The following is a description of a gene set: Human Gene Set: HP_ABNORMALITY_OF_THE_CHIN An abnormality of the chin, i.e., of the inferior portion of the face lying inferior to the lower lip and including the central prominence of the lower jaw. Abnormality of the chin studied in species Homo sapiens, and this is the list of marker genes: BSCL2, PRKAR1A, RMRP, BRAF, FBXL4, VAC14, SETBP1, RAI1, ESAM, SOX11, PIGB (phosphatidylinositol glycan anchor biosynthesis class B), GPR101, LIMK1, PIGY, PTCH1 (NCBI Gene Id 8015), SLC37A4, IL6ST, H4C5, FN1, SLC25A24, CLIC2 (NCBI Gene Id 1193), FBN1, HS2ST1, MESD, DLK1, MEF2C, PMM2, TRIP12, IGF2, GRIA4 (NCBI Gene Id 2893), RERE, STAG2, FLNA, ERCC1, SLC26A2, NGLY1, TFAP2A, SELENON, LUZP1, SLC35A2, APC2, IL11RA, OBSL1, MYH7, HNF1B, FBXO11 (NCBI Gene Id 80204), POLR3A, THOC6, LMNB1, NFIA, TWIST1, CRELD1, PIGU, SMS, DDX59, EIF2S3, STT3A, ZNF526, PCGF2, BICRA, CHRNE, KAT5, P4HTM, NEXMIF, KCNH1, SPOP, GTF2I, GJA5 (gap junction protein alpha 5), FIG4, MYH3, FGD1, GORAB, HERC1, GNB2, PTCH2, UBAP2L, SPECC1L, TAF1, TBX22, SH3PXD2B, COX7B, ZFX, TONSL, CACNA1G, TTC5, IL1RAPL1, CTCF, MEIS2, FLCN, MYH8, EIF4H, IQSEC2, FGF3, GRB10 (NCBI Gene Id 9769), NHS (NCBI Gene Id 907), COA6, SPRED2, AGPAT2, PRDM16, CAVIN1, PRKCZ, OCRL, ARID1B, HRAS, FBXW11, NDUFS4, CHRNG, ATAD3A, UPF3B, NSD2, U2AF2, RNF125, MAN2B1, MBD5, ZNF148, FBXO31, CDC42BPB, DYRK1A, SMC3, MEG3, SRCAP, CHD1, KCTD1, SCUBE3, PTF1A, SLC12A2, ANKRD11, TPRKB, RNF13, CCDC8, MAN1B1, PLOD3, OPHN1, GPC3, NALCN (NCBI Gene Id 93074), SLC6A17, MRAS, PDPN, ERCC4, EHMT1, MTOR, PIGO, TUBGCP4, FKBP6, LTBP3, POC1A, KMT2D, COLQ, CNTNAP2, CBFB (NCBI Gene Id 9163), PIGW, RUSC2, FOS, KNSTRN, LMX1B, PGAP3, ASXL3, FMR1, RNU4-2, NFIX, RALA, CASP2, MEN1, RTL1, ATP10A, NSD1, CLCN3, PAX3, KDM6A, DDR2, NSUN2, TBCK, RNF113A, AHDC1, RPL10, ACBD6 (NCBI Gene Id 84320), ACAN, PAPPA2, AIMP2, PRKG2, SKI, AFF3, NAA10, CLCN4, PGAP2, BUD23, SMAD4, UBE4B, IDUA, SLC35C1, H3-3B, MYOD1, ERI1, DNAJC30, DEAF1 (DEAF1 transcription factor), GPC4, ACTA1, SIN3A, DYM, TAF4, SCNM1, PIGS, BAZ1B, DOCK3, SNRPN, ABL1, CYP26C1, FGFR2, DNM1L, KDM5C, ADAMTSL1, MAF, RPS6KA3, MSTO1, THUMPD1, TBC1D2B, OTUD5, ALDH1A2, HERC2, CAV1, NDST1, POGZ, GJA8, NRCAM, INSR, PIK3CA, SVIL, KIFBP, RUNX2, PIK3CD, VPS37D, PUM1, TBL2, OCA2, PARS2, LRP4, FGFR1, TRIO, ANTXR1, PIEZO2, SFRP4, ZBTB24, SOST (NCBI Gene Id 8149), SETD2, STEEP1, GLB1, KIF7, CSNK2B, SUFU, WDR62, TBC1D7, MED12, EED, HNRNPH1, GFPT1, LZTR1, SMPD4, GABRD, GTF2IRD2, PGM2L1, H3-3A, ERCC8, KDM3B, WAC, ACTB, AIP (aryl hydrocarbon receptor interacting protein), STX1A, SNX14, AP4M1, PPP1R21, TGFB1 (NCBI Gene Id 7040), H19, MAGEL2, MED12L (mediator complex subunit 12L), MAPK1, SUZ12, STXBP1, KCNAB2, TUBGCP6, PUF60 (poly(U) binding splicing factor 60), GALNS, LRP5, SLC4A10, IARS2, CAMTA1, KCNJ6, CDH2, SLC6A8, CRKL, LAMB2, SEMA3E, RNU4ATAC, DHX37, LRP1, SOX18, PTDSS1, ZNF292, METTL27, ADNP, CTU2, KAT6A, ALG13, DHX30, TAFAZZIN, GRIA3, EZH2, FRA10AC1, PTEN, EXOSC5, COL2A1, MED13L, PIGV, SPTBN1, ATRX, UBE3A, SLC9A6, PDCD6IP, LMNA, CHD7, PYCR1, CDH11, TWIST2 (NCBI Gene Id 117581), KIF11, PLAAT3, NOTCH2, PRKDC, CDK10, POU4F1, TTN, DST, SLC10A7, SLF2, HS6ST2, ALG14, NCF1, ANKH, SRRM2, KANSL1, TLK2, GTF2IRD1, RAF1, PORCN, CAMK2B, TMEM270, RFC2, KPTN, RECQL4, COL9A2, CHAMP1, ATP6V1E1, CHD8, DNMT3A, ELN, RFX7, FOXP1, NSRP1, ITCH, PCDHGC4, TMEM94, EBF3, CNOT3, FOXG1, SHANK3, MADD, SMARCA2, HSPG2, PUS7, ACTG1, KDM6B, RAB33B, ASCC3, PRKACB, YY1, ERCC6, SPEN, AP1S2, MGAT2, EXTL3, TXNL4A, GJA1, PIK3R1, PTPN11, UGDH, BCR, CASZ1, APC, AGA, ATP6V0A1, MAP3K7, STAT3, JARID2, PSMB10, NR2F1, CUL7, FAM20C, TNFSF11, ZEB2, PIGL, ZMPSTE24, CUL4B, PQBP1, FLII, XRCC4, CLIP2, BMPR1A, TRPS1, AP4E1, SET, MMP23B, PDE4D, TNNI2, PDGFRB, PLK4 (polo like kinase 4), GNPTAB, PPARG, ADAMTSL4, EDA, MED25 (mediator complex subunit 25)